The following is a description of a gene set: studied in species Homo sapiens Reactome Pathway: Nucleotide salvage defects part of: Diseases of nucleotide metabolism Defects in APRT and HGPRT lead to synthesis of 2,8-dioxo-adenine and overproduction of uric acid, respectively, associated with kidney damage and other symptoms. Defects in ADA lead to accumulation of (deoxy)adenosine and consequent severe combined immunodeficiency., and this is the list of marker genes: ADA, HPRT1, APRT